Given this list of marker genes SLC30A10, SLC11A1, ATP13A1, ATP2C2, SLC11A2, ATP2C1, SLC39A8, SLC39A14, TRPM2, TMEM165, here is a description of the gene set: A process in which a manganese ion is transported from one side of a membrane to the other by means of some agent such as a transporter or pore. studied in species Homo sapiens Human Gene Set: GOBP_MANGANESE_ION_TRANSMEMBRANE_TRANSPORT